Given this list of marker genes IFNAR1, SRGAP2, DNAJA1, CD58, CLVS2, CCDC9B, ADTRP, LYST, BCL2L14, CHRM3, ZNF467, MX1, SEMA4D, ZNF705G, SLC9A9, NCS1, MIR600HG, CYRIA, LINC03086, CDC42EP4, SEMA3C, IRF9, MSANTD3, CYTH3 (NCBI Gene Id 9265), MLPH, MAPT, PIM1, HAND1, CYB5A, MYOM1 (NCBI Gene Id 8736), PLXNC1, SFRP5, ANO2, PIRT, C1orf105, GIMAP4, PLEKHG7, DMXL1, LRTOMT, SH3D19, PBRM1, IRF7, RFTN1, IL4I1, MGC16275, DOHH, SLC1A2, HELZ2, SAT1, TRMT61A (NCBI Gene Id 414769), PRSS50, PLAAT3, AKT3, PLK5, SLAMF7, KREMEN2, CSF2, TPRA1, KLHL4, SYT7, HAO1, LINC02532, OVGP1, HTR2B, LRRC52, TSC22D1-AS1, PHF23, TCP10L, PGGHG, FBXL8, FTH1P5, EFNB1, STAT2, PARP14, PERM1, EPSTI1, KMT2D, OAS3, CLEC14A, DKFZP434A062, CA7, NUPR1, IGF2BP2-AS1, LY75, HERC5, CIMIP2B, SYCP1, ZNF408, SERPINB1, CLDN14, NPAS3, DTX3L, CCIN, SMCO1, ATF5, TDRD7, EPHA7, DUSP21, PLVAP, STAT1, GJB2, ELN, SSTR2, ZC2HC1C, PZP, LARGE-AS1, ATOX1, SLC27A5, SMPD2, MYBL1, LINC01588, ADPGK, DPY19L3-DT, MARCKS, DAND5, DMXL2, MICAL3, PRSS54, C1orf21, CPSF2, SNX15, TOR3A, PLAAT2, SEMA4A, OTOF, PCGF5, GPR32 (G protein-coupled receptor 32), CCR7, LINC01348, RSPRY1, IFIH1, RGS1, ABTB2, LINC01341, CHST7, TPSAB1, RNF213, HLA-F, EPB41, IL12B, BPESC1, KRT83, PARP9, GYG2, G3BP1, PPEF2, LOXL4, TIMD4, UBE2Z, NUB1, SNORC, DHX58, CRYBA4, GSDME, PSAP, GJC2, MREG (NCBI Gene Id 55686), EPCIP-AS1, HIVEP1, MFSD6L, GPM6A, NR2F2-AS1, TRAFD1, TBC1D10A, TNFAIP2, NEURL3, RERG, RNF122, RAVER2, ADAR, C8G, RETREG1, CYB561A3, PRXL2B, PSME2, MYO1G, MMP9, LINC01191, TTYH2, TMEM138, C1orf94, IL9R, B2M, NFE2, STX1B, MUC1, GPR157, EBI3, NRP2 (neuropilin 2), SPACA1, LINC01711, CMTR1, ACOT9, here is a description of the gene set: from publication Gil MP, Ploquin MJ, Watford WT, Lee SH, Kim K, Wang X, Kanno Y, O'Shea JJ, Biron CA (PMID 22968462) Human Gene Set: GSE40666_UNTREATED_VS_IFNA_STIM_STAT1_KO_CD8_TCELL_90MIN_UP Type 1 IFNs can conditionally activate all of the signal transducers and activators of transcription molecules (STATs), including STAT4. The best-characterized signaling pathways use STAT1, however, and type 1 IFN inhibition of cell proliferation is STAT1 dependent. We report that type 1 IFNs can basally stimulate STAT1- and STAT4- dependent effects in CD8 T cells, but that CD8 T cells responding to infections of mice with lymphocytic choriomenigitis virus have elevated STAT4 and lower STAT1 expression with significant consequences for modifying the effects of type 1 IFN exposure. The phenotype was associated with preferential type 1 IFN activation of STAT4 as compared to STAT1. Stimulation through the TCR induced elevated STAT4 expression, and STAT4 was required for peak expansion of antigen-specific CD8 T cells, low STAT1 levels, and resistance to type 1 IFN-mediated inhibition of proliferation. Thus, a mechanism is discovered for regulating the consequences of type 1 IFN exposure in CD8 T cells, with STAT4 acting as a key molecule in driving optimal antigen-specific responses and overcoming STAT1-dependent inhibition of proliferation. Genes up-regulated in CD8 T cells with STAT1: untreated versus interferon alpha. studied in species Homo sapiens